Given this list of marker genes LYRM2, MIURF, MT-ND5, NDUFS3, NDUFA13, BCS1L, NDUFS1, DMAC2, DMAC1, NDUFAF4, ACAD9, NDUFB3, NDUFS5, OXA1L, FOXRED1, NDUFAF7, NDUFS7, NUBPL, ECSIT, TIMM21, NDUFAF6, MT-ND6, NDUFB2, NDUFAF5, NDUFAF2, MT-ND1 (NCBI Gene Id 4535), NDUFAF1, TMEM126A, NDUFS6, NDUFC2, MT-ND2, COA1, NDUFS2, NDUFA6, TMEM70, TIMMDC1, MT-ND4, NDUFS8 (NADH:ubiquinone oxidoreductase core subunit S8), TMEM126B, NDUFAF8, NDUFS4, TMEM186, NDUFAF3, here is a description of the gene set: The aggregation, arrangement and bonding together of a set of components to form an NADH dehydrogenase complex. species: Homo sapiens Human Gene Set: GOBP_NADH_DEHYDROGENASE_COMPLEX_ASSEMBLY